Given this list of marker genes MAPK10, ADCY1, DAGLB, CYP2C9, ADCY7, PRKACG, FAAH, MAPK11 (mitogen-activated protein kinase 11), CYP2C19, MAPK1, MAPK14, AHR, MAPK9, MAPK13, PRKACA, PRKAR1A, PRKAR2B, CNR1 (cannabinoid receptor 1), DAGLA, PRKACB, CYP1A1, CYP3A4, ADORA2A, MAPK12, NAPEPLD, PRKAR1B, MAPK3, CNR2, MAPK8, here is a description of the gene set: studied in species Homo sapiens Human Gene Set: WP_CANNABINOID_RECEPTOR_SIGNALING Cannabinoid receptor signaling